Given this list of marker genes EIF2AK2, NS, here is a description of the gene set: The key role played by PKR in the innate response to virus infection is emphasized by the large number of viruses that encode PKR inhibitors. species: Homo sapiens part of: NS1 Mediated Effects on Host Pathways Reactome Pathway: Inhibition of PKR